Given this list of marker genes DOC2B (NCBI Gene Id 8447), SCAMP5, PPP3CA, SYT10, CDK5R2, RPH3AL, CDK5, STXBP1, SYT1, HYAL3, STX1A, RPH3A, SYT4, SYT7, KCNB1, ZP3, CACNA1B, DOC2A, here is a description of the gene set: Any process that activates or increases the frequency, rate or extent of calcium ion-dependent exocytosis. studied in species Homo sapiens Human Gene Set: GOBP_POSITIVE_REGULATION_OF_CALCIUM_ION_DEPENDENT_EXOCYTOSIS